Given this list of marker genes Cyp7a1, Mtarc2, Cyp3a41b, Slc35d1, Acsm4, Cyp51, Ugt1a1, Cyp46a1, Tpmt, Aoc2, Cyp2u1, Arnt2, Pomc, Mgst2, Nnmt, Ugt2b38, Cyp24a1, Cyp4f39, Cyp3a11, Cyp2a4, Ugt1a9, Cyb5b, Oplah, Cyp2a12, Cyp3a13, Cyp3a41a, Cyp3a16, Ugt2b35, Cyp4a30b, Cyp1b1, Ggt1, Cyp26a1, Ugdh, Ptgis, Cyp11b2, Podxl2, Adh4, Cyp39a1, Cyp4f40, Cyp2f2, Fdx1, Ggt7, Cyp4a29, Fdx2, Acy3, Glyatl3, Cyp4a10 (cytochrome P450, family 4, subfamily a, polypeptide 10), Ugt2b37, Chac1, Gstm1, Cyp4a12a, Acsm2 (NCBI Gene Id 233799), Gsta1, Ces2h, Aldh3a1, Cyp3a44, Cyp2e1, Cyp2d22, Cmbl, Cyp2c55, Dpep1, N6amt1, Cyp3a25, Tbxas1, Dpep2, Cyp8b1, Aoc3, Nat2, Ugt3a1, Ugt1a5, Ugp2, Gsta2, Sult1b1, Cyp2c66, Nat3, Gstt2, Acsm1, Adh5, Cyp4b1, Mtrr, Ptgs1, Mtarc1, Abhd10, Acsm5, Sult1c2, Gsta3, Cyp1a1, Cyp4f15, Cyp19a1, Ugt2b1, Bpnt1, Aldh2, Gsta13, Ggt5 (gamma-glutamyltransferase 5), Cyp3a57, Ggt6, Hpgds, Gstm2, Mat1a, Ugt2b36, Nat1, Cyp26b1, Ugt1a7c, Ces1d, Gstp1, Ncoa1, Cyp4v3 (NCBI Gene Id 102294), Cyp1a2, Fmo1, Chac2, Mat2a, Cyp4f18, Ugt1a8, Ugt2a2, Ces3a, Gstm5, Cyp4a31, Trmt112, Ugt2a1, Ces3b, Ugt1a6a, Ugt2a3, Aldh1b1, Nr1h4, Fdxr (ferredoxin reductase), Sult6b1, Nqo2, Gstz1, Gstt1, Cyp2c65, Cyp2j6, Gstm6, here is a description of the gene set: This event has been computationally inferred from an event that has been demonstrated in another species.<p>The inference is based on the homology mapping from PANTHER. Briefly, reactions for which all involved PhysicalEntities (in input, output and catalyst) have a mapped orthologue/paralogue (for complexes at least 75% of components must have a mapping) are inferred to the other species. studied in species Mus musculus part of: Metabolism electronically inferred by orthology from the curated human pathway Reactome Pathway: Biological oxidations